Given this list of marker genes PRPF31, TXNL4A, SF3B5, LSM6, SNRPB, SNRPGP15, LSM2, LSM7, SF3B1, LSM4, SNRNP200, EFTUD2, PRPF3, SF3A1, SRRM2, SNRPE, SNRPD1, ZMAT2, CWC22 (NCBI Gene Id 57703), SF3B2, PRPF4, PHF5A (PHD finger protein 5A), LSM3, PRPF6, SNRPD3, SF3B4, SF3A2, CWC27, WBP4, MAGOHB, BUD13, SNU13, MFAP1, PRPF38B, SF3B3, LSM8, SMU1, SNRPF, SF3A3, RNF113A, RBMX2, SART1, PRPF8, PRPF38A, LSM5, SNRPB2, DHX16, SNRPG, SNRPA1 (small nuclear ribonucleoprotein polypeptide A'), IK, SNIP1, SNRPD2, here is a description of the gene set: Human Gene Set: GOCC_PRECATALYTIC_SPLICEOSOME species: Homo sapiens A spliceosomal complex that is formed by the recruitment of a preassembled U5-containing tri-snRNP to the prespliceosome. Although all 5 snRNPs are present, the precatalytic spliceosome is catalytically inactive. The precatalytic spliceosome includes many proteins in addition to those found in the associated snRNPs.